The following is a description of a gene set: Mouse Gene Set: GOMF_MANNOSYL_OLIGOSACCHARIDE_1_2_ALPHA_MANNOSIDASE_ACTIVITY Catalysis of the hydrolysis of the terminal (1->2)-linked alpha-D-mannose residues in an oligo-mannose oligosaccharide. studied in species Mus musculus, and this is the list of marker genes: Man1c1, Edem3, Edem1, Edem2, Man1a2 (NCBI Gene Id 99756), Man1a, Man1b1